Given this list of marker genes CALM1, DHFR, GCHFR, GCH1, NOS3, AKT1, PRKG2, HSP90AA1, SPR, PTS, here is a description of the gene set: species: Homo sapiens Tetrahydrobiopterin (BH4) is an essential co-factor for the aromatic amino acid hydroxylases and glycerol ether monooxygenase and it regulates nitric oxide synthase (NOS) activity. Inherited BH4 deficiency leads to hyperphenylalaninemia, and dopamine and neurotransmitter deficiency in the brain. BH4 maintains enzymatic coupling to L-arginine oxidation to produce NO. Oxidation of BH4 to BH2 results in NOS uncoupling, resulting in superoxide (O2.-) formation rather than NO. Superoxide rapidly reacts with NO to produce peroxynitrite which can further uncouple NOS.<br>These reactive oxygen species (superoxide and peroxynitrite) can contribute to increased oxidative stress in the endothelium leading to atherosclerosis and hypertension. The synthesis, recycling and effects of BH4 are shown here. Three enzymes are required for the de novo biosynthesis of BH4 and two enzymes for the recycling of BH4. Reactome Pathway: Tetrahydrobiopterin (BH4) synthesis, recycling, salvage and regulation part of: Metabolism of cofactors